Given this list of marker genes CHST7, LETMD1, PRXL2C, MRPL45, LYAR, ANG, EML4, BLK, AKT2, MAP3K7, HNRNPA0, SARAF, ERCC6L2, EPS8L1, LACC1, CAPNS1, NCK2, RPL26, XRCC1, UBE2M, AGMO, GRAMD4, HLA-B, NAA38, SOCS2, HOOK2, SNHG6, PPM1H, VCPIP1, STAR, TJP2, CCNYL1, SEPSECS, USP4, BCAM, RBM42, SLC25A51, RALGAPB, ADM, PFKFB3, WDHD1, ZNF213, BRPF1, IL3RA, NDUFAF7, MRPS30, CCND1, PCM1, TGM2, CEP63, CD19, ATOSA, CISD3, PHB2, APOC2, NFE2L2, TSPOAP1, BCAR3, SLC7A2, LXN, CNN3, LYRM4, NR2C2AP, CCL22, ZNF619, CACNB3, TNFAIP8, HSP90AB1, SLC7A1, MGA, ZMYND8, HSD11B1, SIGLEC10, ROMO1, CLEC4G, NCAPG2 (non-SMC condensin II complex subunit G2), SWAP70, CDC25A, ACVR1B, TAP1, ADGRG6, DMPK, DHX15, CLEC1B, MYO1G, NOCT, RSAD1, COP1, P2RX7, TMEM123, HARS1, PINK1 (PTEN induced kinase 1), RBBP8, NAA16 (NCBI Gene Id 79612), SDCCAG8, CD36, ABTB3, ZDHHC3, STAP2, RAB19, OSR2, PRKCD, CYB5R4 (NCBI Gene Id 51167), TNFRSF4, MAP1S, ALAS1, OVCA2, NEURL1B, UBASH3B, GSR, CDV3, ARL5A, ANXA3, MBNL3, ATF7IP, AGBL3, RNF187, S1PR3, ELOVL7 (NCBI Gene Id 79993), FOXO1, ZC3H12D, LSP1, PDS5A, TOMM6, RPS14, STAT4, TKT, PHLDA3, MREG, B3GNT5, PFN2, ABCC1, MAP7, RPSA, GNRHR, RAB7A, HMGA2, CD180, HMGB1, MID1, CHAC1, ETV3, ZC3H8, SEC61B, ZNF490, INTU, BTLA, NELFA, OCIAD1, PLEKHG1, HMGA1, RPL39L, MRPL44, ARHGAP31, LSM4, NOD1, MFAP3, IL21R, ACAA1, SMARCA4, CEP192 (centrosomal protein 192), AFG2B (NCBI Gene Id 80051), FABP5, CPSF3, CCDC25, SHC1, PRCP, NDUFB4, NDUFA13, PLEKHJ1, EIF3A, SPINT1, INPP1, TNFAIP3, FAM219A, SNRNP48, TEP1, B4GALT5, PAPSS2, PPP4R3A, SUPT5H, MCM3, NDE1, POLD1, RPL35, PADI2, TMEM108, SAV1, GRIA3, FAM111A, FAM20C (NCBI Gene Id 56975), TMEM81, NLRC5, NPC1, NCAPH, TTC4, RIOX2, CDC7, KCNIP3, METTL23 (methyltransferase 23, arginine), here is a description of the gene set: from publication Liu PT, Stenger S, Li H, Wenzel L, Tan BH, Krutzik SR, Ochoa MT, Schauber J, Wu K, Meinken C, Kamen DL, Wagner M, Bals R, Steinmeyer A, Zügel U, Gallo RL, Eisenberg D, Hewison M, Hollis BW, Adams JS, Bloom BR, Modlin RL (PMID 16497887) Human Gene Set: GSE8921_UNSTIM_VS_TLR1_2_STIM_MONOCYTE_12H_DN In innate immune responses, activation of Toll-like receptors (TLRs) triggers direct antimicrobial activity against intracellular bacteria, which in murine, but not human, monocytes and macrophages is mediated principally by nitric oxide. We report here that TLR activation of human macrophages up-regulated expression of the vitamin D receptor and the vitamin D-1-hydroxylase genes, leading to induction of the antimicrobial peptide cathelicidin and killing of intracellular Mycobacterium tuberculosis. We also observed that sera from African-American individuals, known to have increased susceptibility to tuberculosis, had low 25-hydroxyvitamin D and were inefficient in supporting cathelicidin messenger RNA induction. These data support a link between TLRs and vitamin D-mediated innate immunity and suggest that differences in ability of human populations to produce vitamin D may contribute to susceptibility to microbial infection. species: Homo sapiens Genes down-regulated in monocytes (12h): untreated versus M. tuberculosis 19 kDa lipopeptide.